The following is a description of a gene set: species: Mus musculus Cam-PDE 1 activation Mouse Gene Set: REACTOME_CAM_PDE_1_ACTIVATION, and this is the list of marker genes: Pde1a, Pde1b, Pde1c, Calm2, Calm3, Calm1